Given this list of marker genes MAT1A, SLC16A2, GOT2 (NCBI Gene Id 2806), CUX2, ACSM5, DMD, EPHX2, ETFDH, RCL1, CFI, F8, ALAS1, SEC14L2, DCXR, RIDA, SLC4A4, ECHDC2, PROZ, SLC28A1, GRHPR, EXPH5, HPD, FGA, ACAA2, PRODH2, HADH, SLC27A5, HAO1 (hydroxyacid oxidase 1), ST3GAL6, HYAL1, ECM2, RGN, MTHFD1, NR1I2, SLC6A12, GCDH, ASPA, MLYCD, PSD3, ACAA1 (NCBI Gene Id 30), ETNK2, GABARAPL3 (NCBI Gene Id 84655), CBR4, MSRA, ITIH4, PCK2, ACADL, SLC25A15, FAS, GABARAPL1, FYN, here is a description of the gene set: Human Gene Set: BOYAULT_LIVER_CANCER_SUBCLASS_G123_DN Hepatocellular carcinomas (HCCs) are a heterogeneous group of tumors that differ in risk factors and genetic alterations. We further investigated transcriptome-genotype-phenotype correlations in HCC. Global transcriptome analyses were performed on 57 HCCs and 3 hepatocellular adenomas and validated by quantitative RT-PCR using 63 additional HCCs. We determined loss of heterozygosity, gene mutations, promoter methylation of CDH1 and CDKN2A, and HBV DNA copy number for each tumor. Unsupervised transcriptome analysis identified 6 robust subgroups of HCC (G1-G6) associated with clinical and genetic characteristics. G1 tumors were associated with low copy number of HBV and overexpression of genes expressed in fetal liver and controlled by parental imprinting. G2 included HCCs infected with a high copy number of HBV and mutations in PIK3CA and TP53. In these first groups, we detected specific activation of the AKT pathway. G3 tumors were typified by mutation of TP53 and overexpression of genes controlling the cell cycle. G4 was a heterogeneous subgroup of tumors including TCF1-mutated hepatocellular adenomas and carcinomas. G5 and G6 were strongly related to beta-catenin mutations that lead to Wnt pathway activation; in particular, G6 tumors were characterized by satellite nodules, higher activation of the Wnt pathway, and E-cadherin underexpression. CONCLUSION: These results have furthered our understanding of the genetic diversity of human HCC and have provided specific identifiers for classifying tumors. In addition, our classification has potential therapeutic implications because 50% of the tumors were related to WNT or AKT pathway activation, which potentially could be targeted by specific inhibiting therapies. studied in species Homo sapiens Down-regulated genes in hepatocellular carcinoma (HCC) subclass G123, defined by unsupervised clustering. from publication Boyault S, Rickman DS, de Reyniès A, Balabaud C, Rebouissou S, Jeannot E, Hérault A, Saric J, Belghiti J, Franco D, Bioulac-Sage P, Laurent-Puig P, Zucman-Rossi J (PMID 17187432)